Given this list of marker genes GDF3, WNT11, GLI1, EPHA2, CRB2, COL2A1, NOG, EFNA1, SOX9, TEAD2, COBL, NCKAP1, NOTO, PPP1R35, ID3, STIL (STIL centriolar assembly protein), WNT5A, YAP1, here is a description of the gene set: The process whose specific outcome is the progression of the notochord over time, from its formation to the mature structure. The notochord is a mesoderm-derived structure located ventral of the developing nerve cord. In vertebrates, the notochord serves as a core around which other mesodermal cells form the vertebrae. In the most primitive chordates, which lack vertebrae, the notochord persists as a substitute for a vertebral column. species: Homo sapiens Human Gene Set: GOBP_NOTOCHORD_DEVELOPMENT